Given this list of marker genes Pah, Pcbd1, Asrgl1, here is a description of the gene set: This event has been computationally inferred from an event that has been demonstrated in another species.<p>The inference is based on the homology mapping from PANTHER. Briefly, reactions for which all involved PhysicalEntities (in input, output and catalyst) have a mapped orthologue/paralogue (for complexes at least 75% of components must have a mapping) are inferred to the other species. studied in species Mus musculus Reactome Pathway: Phenylalanine metabolism part of: Phenylalanine and tyrosine metabolism electronically inferred by orthology from the curated human pathway